Given this list of marker genes F9, F10, F11, GP5 (glycoprotein V platelet), GP1BA, GP9, F8, GP1BB (NCBI Gene Id 89199), GGCX, here is a description of the gene set: part of: Defects of Coagulation cascade The F9 gene encodes coagulation factor IX (FIX), a vitamin K-dependent plasma protease that participates in the intrinsic blood coagulation pathway. FIX circulates as a zymogen, and is proteolytically activated to FIXa by activated FXIa or tissue factor-bound FVIIa. After being activated, FIXa forms a complex with Ca2+ ions, membrane phospholipids and coagulation factor VIIIa to activate coagulation factor X. Mutations within F9 gene that lead to quantitative and/or qualitative deficiencies in the circulating FIX protein are associated with hemophilia B (HB), a rare X-linked, recessively transmitted bleeding disorder (White GC et al. 2001; Rallapalli PM et al. 2013; Goodeve AC 2015). The disease severity in hemophilia is classified according to the plasma procoagulant levels of FIX activity. The severe form is defined as a factor level <1% of normal, the moderate form as a factor level of 1-5%, and the mild form with a factor level >5 and <40%. Patients with severe hemophilia frequently develop hemorrhages into joints, muscles or soft tissues without any apparent cause. They can also suffer from life-threatening bleeding episodes such as intracranial hemorrhages. Persons with mild and moderate factor deficiency rarely experience spontaneous hemorrhages, and excessive bleeding mostly occurs only following trauma or in association with invasive procedures.<p>A wide range of different genetic alterations are spread throughout the F9 gene, including single nucleotide substitutions, small and large deletions (Rallapalli PM et al. 2013). However functional consequences of most F9 mutations are poorly studied. The annotated HB-associated FIX variants are supported with data from functional studies (Usharani P et al. 1985; Spitzer SG et al. 1990; Ludwig M et a. 1992; Kurachi S et al. 1997; Branchini A et al. 2013). studied in species Homo sapiens Reactome Pathway: Defective factor IX causes hemophilia B